Given this list of marker genes Akt1, Sik3, Otud7b, Otud5, Usp9x, Ep300, Tbk1, Nckap1l, here is a description of the gene set: Mouse Gene Set: GOBP_POSITIVE_REGULATION_OF_TORC2_SIGNALING Any process that activates or increases the frequency, rate or extent of TORC2 signaling. studied in species Mus musculus